The following is a description of a gene set: species: Homo sapiens The process in which the anatomical structures of a dendritic tree are generated and organized into dendritic branches. Human Gene Set: GOBP_DENDRITE_ARBORIZATION, and this is the list of marker genes: TAOK2, SEMA3A, ATG16L1, SULT4A1, TPBG, ZNF365, NRP1, PTN, CHRNA7, PHACTR1, CC2D1A, IGF2BP1